The following is a description of a gene set: Human Gene Set: WP_ARYLAMINE_METABOLISM studied in species Homo sapiens Arylamine metabolism, and this is the list of marker genes: UGT1A9, NAT2, SULT1A2 (NCBI Gene Id 6799), SULT1A1, CYP1A2, UGT1A4